The following is a description of a gene set: studied in species Mus musculus Mouse Gene Set: GOMF_TELOMERIC_DNA_BINDING Binding to a telomere, a specific structure at the end of a linear chromosome required for the integrity and maintenance of the end., and this is the list of marker genes: Rad50, Wrn, Rpa2, Zbtb10, Xrcc5, Tert, Smg7, Tinf2, Pura, Zbtb48, Upf1, Smg6, Upf2, Hnrnpa1, Ten1, Stn1, Telo2, Acd, Apex1, Hnrnpd, Purb, Pif1 (PIF1 5'-to-3' DNA helicase), Hmbox1, Trp53bp1, Pot1b, Terf2ip, Ctc1, Terf2, Smg5, Blm, Nabp2, Rpa1, Hnrnpa2b1, Xrcc6, Pot1a, Ncl, Smg1, Terf1, Upf3a